Given this list of marker genes Pth, Ppp1r3g, Pth1r, Mup5, Ppp1r3e, Prkaca, Slc25a12, Pdgfb, P2rx7, Lhcgr, Wdr5, Oprm1, Arnt, Irs1, Pfkfb1, Ppp1r3b, Ppara, Tcf7l2, Dgat2, Ifng, Sirt1, Hnf4a, Ptafr, Has2, Gck, Nnmt (NCBI Gene Id 18113), Rgn, Mlx (MAX-like protein X), Mlxipl, Adra1b, Adcy10, P2ry1, Igf2, Phkg1, C1qtnf2, Supt20, Snca, Insr, Phkb, Ptpn2, Ppp1ca, Mup3, Akt2, Ppp4r3a, Mlst8, Mup11, Phkg2, Ntsr1, Gcg, P2ry6, Stk11, Mup4, Ppp2ca, Cry1, Myc (NCBI Gene Id 17869), Gper1, Egf (epidermal growth factor), Irs2 (insulin receptor substrate 2), Gpld1, Foxo1, Prkag3, Ptger4, Akt1, Ddb1, App, Slc4a4, Kat2b, Esrrb, Arpp19, Avpr1b, Ppp4r3b, Mas1, Hif1a, Rptor, Mtor, Prkag1, Igf1, Gpi1, Htr2a, Cd244a, Slc45a3, Gpt, Prkaa1, Gapdhs, Prxl2c, Prkag2, Epm2aip1, Myh9, Ins2, Ins1, Psen1, Sorbs1, Kat2a, Mup2, Phka1, Plcd1, Dyrk2, Sirt7, Cyp2j6, Mup1, Actn3, Gpd1, Adcyap1r1, Nfkb1, Hmgb1, Uchl1, Pou1f1, Sik2, Prkaa2, Src, Zbtb20, Pmaip1 (phorbol-12-myristate-13-acetate-induced protein 1), here is a description of the gene set: Mouse Gene Set: GOBP_POSITIVE_REGULATION_OF_CARBOHYDRATE_METABOLIC_PROCESS Any process that activates or increases the frequency, rate or extent of the chemical reactions and pathways involving carbohydrate. studied in species Mus musculus